Given this list of marker genes PHB1, CDKN2C, FRZB, INHBA, ENPP1, G6PD, DIP2B, TRIM40, OSGIN2, PPARA, NME6, EPHA7, BMP10, TOMM70, GDF2, TCHP, RACK1 (NCBI Gene Id 90938), MEG3, DDX3X, SEMA3G, TMEM196, ESR2, RB1, GSK3A, WNT3, CDK5, DCUN1D3, CDKN2AIP, HSPA1A, ATG16L1, ULK2, WT1, TSPYL2, SLIT1, RGS4, BMPR2, SESN2, IFRD1, NPPB, RNF6, PPP1R9B, NPR1, MINAR1, ACVR1B, P3H1, DAB2, BCL11A, NTN1, RERG, MSX1, ACVRL1, PRDM11, TGFB1, KIAA0319, CCAR2, PPT1, HYAL1, NDRG3 (NCBI Gene Id 64401), MT3, HDAC6, NPPA, TP53, TGFB2, CDH1, SFRP2, ING1, TRIM46, RBBP7 (NCBI Gene Id 5931), SPP1, JADE1, CDKN1B, DCC, SCGB3A1, BRCA1, OSGIN1, AGTR2, SERPINE2, ENO1, IP6K2, BST2, DCBLD2 (discoidin, CUB and LCCL domain containing 2, NCBI Gene Id 131566), CAPRIN2, SEMA5A, GNG4, SLIT3, DCSTAMP, CDKL3, EI24, CCN3, HYAL2, GJA1, DNAJB2, RTN4R, DRAXIN, FOXP1, RYK, BTG1, CAV3, SESN1, EAF2, SIPA1, VGLL4, CDKN2D, CYP27B1, ST7L, SLIT2, MAG, CRLF3, SERTAD3, SPAG9, FSTL4, CFL1, ZC3H12D, SEMA6C, ULK1, CDA, STK11, SEMA6D, MAP2, ADAM15, WNT3A, CGRRF1, WNT5A, SOX17, SMAD3, PAK1, RGS2, BDKRB1, TP53TG5, CDKN1A, SEMA4F, MIR199B, FGF13, SERTAD2, PLXNA3, PTPRS, SPHK2, HNF4A, MYL2, DACT3, TNR, SPART, MIR199A1, HSPA1B, HRG, FBP1, ARHGAP4, ADIPOR1, CDKN2A, NAIF1, CCDC85B (coiled-coil domain containing 85B), OSTN, PSRC1, BCL6, BCL2, NRP1, PML, CDHR2, PTPRJ, GDF9, SH3BP4, CTDP1, WFDC1, FHL1, SMARCA2, SFRP1, SEMA3F, SMAD4, PPARD, RGMA, YY1, PI16, SMARCA4, CRYAB, RTN4, here is a description of the gene set: Any process that stops, prevents, or reduces the frequency, rate, extent or direction of cell growth. studied in species Homo sapiens Human Gene Set: GOBP_NEGATIVE_REGULATION_OF_CELL_GROWTH